The following is a description of a gene set: Human Gene Set: GOBP_OTIC_VESICLE_FORMATION The process resulting in the transition of the otic placode into the otic vesicle, a transient embryonic structure formed during development of the vertebrate inner ear. species: Homo sapiens, and this is the list of marker genes: CEP290, FGF8, PROX1, FGFR2, TCAP, HESX1, SOX9, FGF10